Given this list of marker genes TNFRSF18, HSF1, GCH1, ODC1, PLBD1, S100A9, NABP1, SRM, ANXA6, RORB, RBM6, KBTBD11, FBXW12, PDPN, RALGDS, H2AL3, MT1F, CTSV, TRNT1, STK35, SELENOS, PTBP1, MT1X, SPRR1A, NME1, CRNKL1, TMCO5A, ADAR, RRAD, EDF1, LSM8, BPIFA1, MAT2A, FBXL9P, CREB3, SLPI, SCGB1A1, JUNB, S100A8, KRT88P, here is a description of the gene set: Human Gene Set: SCHLINGEMANN_SKIN_CARCINOGENESIS_TPA_UP species: Mus musculus Up-regulated in murine dorsal skin cells at 6 h after treatment with the phorbol ester carcinogen TPA. from publication Schlingemann J, Hess J, Wrobel G, Breitenbach U, Gebhardt C, Steinlein P, Kramer H, Fürstenberger G, Hahn M, Angel P, Lichter P (PMID 12640676) Malignant transformation of mouse skin by chemical carcinogens and tumour promoters, such as the phorbol ester 12-O-tetradecanoylphorbol-13-acetate (TPA), is a multistage process that leads to squamous cell carcinoma (SCC) formation. In an effort to identify tumour-associated genes, we studied the influence of short-term TPA-treatment on the gene expression profile of murine skin. A comprehensive microarray with some 5,000 murine gene specific cDNA fragments was established and hybridised with pooled RNA derived from control and TPA-treated dorsal skin samples. Of these genes, 54 were up- and 35 were down-regulated upon TPA application. Additionally, we performed suppression subtractive hybridisation (SSH) with respective RNA pools to generate and analyse a cDNA library enriched for TPA-inducible genes. Expression data of selected genes were confirmed by quantitative real-time PCR and Northern blot analysis. Comparison of microarray and SSH data revealed that 26% of up-regulated genes identified by expression profiling matched with those present in the SSH library. Besides numerous known genes, we identified a large set of unknown cDNAs that represent previously unrecognised TPA-regulated genes in murine skin with potential function in tumour promotion. Additionally, some TPA-induced genes, such as Sprr1A, Saa3, JunB, Il4ralpha, Gp38, RalGDS and Slpi exhibit high basal level in advanced stages of skin carcinogenesis, suggesting that at least a subgroup of the identified TPA-regulated genes may contribute to tumour progression and metastasis.